Given this list of marker genes KRIT1, NF2, CCM2, PDCD10, PIK3CA, NF1, here is a description of the gene set: species: Homo sapiens Human Gene Set: HP_NEUROMA Neuroma A tumor made up of nerve cells and nerve fibers.